The following is a description of a gene set: Human Gene Set: MIKKELSEN_MEF_HCP_WITH_H3_UNMETHYLATED Genes with high-CpG-density promoters (HCP) with unmethylated histone H3 in MEF cells (embryonic fibroblast). species: Mus musculus from publication Mikkelsen TS, Ku M, Jaffe DB, Issac B, Lieberman E, Giannoukos G, Alvarez P, Brockman W, Kim TK, Koche RP, Lee W, Mendenhall E, O'Donovan A, Presser A, Russ C, Xie X, Meissner A, Wernig M, Jaenisch R, Nusbaum C, Lander ES, Bernstein BE (PMID 17603471) We report the application of single-molecule-based sequencing technology for high-throughput profiling of histone modifications in mammalian cells. By obtaining over four billion bases of sequence from chromatin immunoprecipitated DNA, we generated genome-wide chromatin-state maps of mouse embryonic stem cells, neural progenitor cells and embryonic fibroblasts. We find that lysine 4 and lysine 27 trimethylation effectively discriminates genes that are expressed, poised for expression, or stably repressed, and therefore reflect cell state and lineage potential. Lysine 36 trimethylation marks primary coding and non-coding transcripts, facilitating gene annotation. Trimethylation of lysine 9 and lysine 20 is detected at satellite, telomeric and active long-terminal repeats, and can spread into proximal unique sequences. Lysine 4 and lysine 9 trimethylation marks imprinting control regions. Finally, we show that chromatin state can be read in an allele-specific manner by using single nucleotide polymorphisms. This study provides a framework for the application of comprehensive chromatin profiling towards characterization of diverse mammalian cell populations., and this is the list of marker genes: IL1RAPL2, L1TD1, CACNG2, RBM28, PCDHA8, ZNF385A, TRPM6, GIGYF1, KCNE5, RBFOX1, LGI3, GPR101, PAPOLB, SYCP2, FAR2, CES5A, PCDHA4, HENMT1, NRSN1, MAP7D2, RPH3A, LAG3, TRPC3, RCVRN, OMP, MYH14, B3GNT8, SLITRK4, NPAS4, TEX101, BCL2L10, APOC1, LDHAL6B, VSIR, SOX15, ADAM1A, PCDHB10, DPEP3, BRDT, CRYGA, PCDHA7, PCDHB14, CCDC83, SLC15A3, SPIRE1, NPB, TEKTIP1, NSMCE3, FGF22, PLAAT1 (NCBI Gene Id 57110), SYP, SYCP1, ARX, ACTL7B, NXPH2, SH3D19, THEM7P, NHERF4 (NCBI Gene Id 79849), TSSK2, HMGCLL1, PCDHA3, CAMKK2, DLGAP1, PRSS44P (serine protease 44, pseudogene), FSCN2, DHDH, PCDHB5, DMRTC1, SAP25, C10orf67, C19orf67, SCG3, NR0B1, SYCP3, LKAAEAR1, LYPD2, PLCE1, IRS4, PLVAP, PTGIR, RHBDL1, KRT18, SPAG6 (NCBI Gene Id 9576), GFAP, TAF7L, ILDR1, IL12RB2, DPP6, WBP2NL, CLVS1, DROSHA, ASZ1, ADAM32, GSN, PCDHA10, CHST6, TM6SF2, ACRBP, SLC26A8, ABHD16B, BHLHA15, TLE6, SPAG8, GTF2A1L, PCDHB7, NLGN2, HSPB3, DMC1, CCIN, NOS1, PCDHB18P, TBX22, TNFAIP8L2, EZHIP, POU3F4, DNAJB8, C5orf47, DND1, ADAMTSL1, HOXA3, STRA8, SPAG16 (NCBI Gene Id 79582), NSD1, TEX13B, SSTR2, HTR5A, TRPM1 (transient receptor potential cation channel subfamily M member 1), MTNR1A (melatonin receptor 1A), FGF6, SLC2A5, DEUP1, MYCN, DUSP13B, C3orf62, MSH4, KLK10, SYNPR, SLC2A9, BASP1, TNFSF13B, KRT2, SLC25A31, LTB4R, LY6K, GNMT, COL9A3, REC8, CNGA4, PLCXD1, MAGIX, GPR182, CNTNAP2, KRT26, PCDHA13, GLRA1, EDN3 (endothelin 3), CAMK2A, PCSK1N, ARHGAP4, CHAD, EPPK1, TKTL2 (transketolase like 2), THSD7B, CNIH2, BEX1, PIWIL1, SPESP1, RNF225, PABPC3, PCDHA2, VWA1, SOX3, SPEG, PCDHA9, NECAB1, CLVS2, FXYD2, ADAM1B, OLFM3, PCDHA11, HSF5, RBP3, CCDC185, TMC8, GPR158, PCDHB1, LDOC1, ZNF516, CCDC110, TDRD1, PCDHA1, IL20RB, ZFTA, TEX19, BEX4, RNF17, HTR2C, CHRM4, SOHLH2, RIIAD1, GDAP1, SPMAP1, KRT27, KCNV2, RHO, SLC35F4, FAM178B, MAEL, CDX4, TEX12, KCNJ11, EPHA1, PRSS45P, GABRQ, SCG5, MARVELD2, PCDHA5, BAHCC1, JAK3, RAB9B, PTPN6, GPR50, CHRDL1, KRT85, MGAT4D, NAA11, FSTL5, DDX4, KRT4, PDHA2 (NCBI Gene Id 5161), PCDHAC1, HORMAD2, ASPHD2, TEX11, CRYBB3, IGSF1